Given this list of marker genes CD3E, ZAP70 (zeta chain of T cell receptor associated protein kinase 70), NFATC3, PLCG1, CD3G, CD8A, PRF1, PAG1, SLA2, CXCL10, CD247, NFATC2, FYN, CD3D, RASGRP1, NFATC1, LAT, PRKCQ, RASGRP2, CXCL9, MAP4K1, CD8B, LCK, here is a description of the gene set: Adjuvanted vaccines afford invaluable protection against disease, and the molecular and cellular changes they induce offer direct insight into human immunobiology. Here we show that within 24 h of receiving adjuvanted swine flu vaccine, healthy individuals made expansive, complex molecular and cellular responses that included overt lymphoid as well as myeloid contributions. Unexpectedly, this early response was subtly but significantly different in people older than ~35 years. Wide-ranging adverse clinical events can seriously confound vaccine adoption, but whether there are immunological correlates of these is unknown. Here we identify a molecular signature of adverse events that was commonly associated with an existing B cell phenotype. Thus immunophenotypic variation among healthy humans may be manifest in complex pathophysiological responses. from publication Sobolev O, Binda E, O'Farrell S, Lorenc A, Pradines J, Huang Y, Duffner J, Schulz R, Cason J, Zambon M, Malim MH, Peakman M, Cope A, Capila I, Kaundinya GV, Hayday AC (PMID 26726811) Human Gene Set: SOBOLEV_T_CELL_PANDEMRIX_AGE_18_64YO_1DY_UP Genes up-regulated in T cell 1d vs 0d in adults (18-64) after exposure to Pandemrix (A/California/7/09 (H1N1)), time point 1D. Comment: - roughly 60/40 female:male ratio, over 70% were Causasian species: Homo sapiens